The following is a description of a gene set: from publication Yevshin I, Sharipov R, Kolmykov S, Kondrakhin Y, Kolpakov F (PMID 30445619) studied in species Mus musculus Mouse Gene Set: DNAJC2_TARGET_GENES Genes containing one or more binding sites for (Dnajc2) in their promoter regions (TSS -1000,+100 bp) as identified by GTRD version 20.06 ChIP-seq harmonization., and this is the list of marker genes: Dgkz, Atn1, Nktr, E2f2, Sbds, Slc38a1, Amdhd2, Ipo9, Zbtb48, Pgk1, 4930429F24Rik, Ccm2, Napg, Map3k9, Acd, Gm13337, Hspa5, Fgfr3, Itga2b, Gm16121, Trp53i13, Ppp5c, Lamtor4, Tektip1, Nicol1, Por, Arhgef15, Gnat1, Kcnd3, Tyw1, Abhd15, Fasn, Tbcb, Myrip, Polr2i, Mir3102, Xkr8, Kcnd3os, Shd, Tiam2, Npw, Srrm3, Sgca, Atp4a